The following is a description of a gene set: studied in species Homo sapiens Genes having at least one occurence of the motif CATTTCA in their 3' untranslated region. The motif represents putative target (that is, seed match) of human mature miRNA hsa-miR-203 (v7.1 miRBase). Human Gene Set: CATTTCA_MIR203, and this is the list of marker genes: SLC7A14, GPATCH1, CHST7, CAPN3, CPEB4 (cytoplasmic polyadenylation element binding protein 4), DPY19L4, INA, PLAA, COL17A1, IGFBP5, ELL2, KRT35, ANP32E, ZNF532, XKR6, APRG1, GLRB, BTBD7, RPGRIP1L, ID4, RERG, WDFY3, OSBPL8, OVOL1, ETS2, BMERB1, SRSF1, EGR3, PRICKLE2, PRKCA, TMEM248, ATG14 (autophagy related 14), KHDRBS1, KRT85, TRPV3, AP1G1, PDE4D, NAA25, NUFIP2, CSNK1A1, RAPGEF4, NXPH1, HIPK1, ACO2, SOSTDC1, KIAA0930, MAGI1, LAMP2, API5, ALDH1A2, SEC24D, PURB, CCDC178, PTPN3, CTDSPL2, YWHAQ, ATP5MC3, CITED2, XPO4, LIMCH1 (LIM and calponin homology domains 1), SESTD1, ITPR2, SLC1A2, EPC2, GPR180, ID2B, APPL1, PTPRG, ABL1, PLD2, ETV1, SPIRE1, NDRG3, EIF4E, STX16, KLF12, PRKG1, NBEA, PRPS2, UBR3, CCNG1, KRT1, AFF4, TAF1D, RAB10, MACIR, HYCC2, TRPS1, BMAL1, RAP1A, MORF4L1 (NCBI Gene Id 10933), XYLT1, DCUN1D3, ACVR2A, FERRY3, PPP1R12A, CUL1, RAPH1, SRC, MBLAC2, STEAP1, DYRK1A, CLRN1, VAV3, CLUH, ARID1A (NCBI Gene Id 8289), SEPTIN3, CSRNP2, SPEN, AFAP1L2, GRHL3, ADAMTS6, ZFC3H1, VCAN, NUMBL, DGKB, NKRF, ID2, NUAK1, SLC12A2, EGR1, SLC39A9, GLCCI1, TASP1, CDH10, RARB, BPTF, NAA30, RNF38, TWF1, KIF2A, SMAD1, ZRANB2, SMURF1, AHR, R3HDM1, CCNC, MBD6, LRRC37A6P, SOCS6, SYNJ1, NLK, KCTD9, GNAO1, EBF3, DUSP5, FOXG1, FMNL2, ATP2B2, PDAP1, FOXK1, H3-3A, APC, TSC22D1, VAT1 (NCBI Gene Id 10493), MEX3C, MAP4K3, DGKZ, KPNB1, AP2B1, NEGR1, VAPA, PDSS2, XRN2, FOXK2, SGK3, NAA50 (NCBI Gene Id 80218), RNF34, CAB39, SIK1, ATM, EGLN1, CREBZF, SOCS3, PLPP3, SLC4A4, ZMIZ1, PCDH19, TUSC2, MBNL2, PRKCB, CLASP2, INSIG1, PCSK1, ZMYM4, LMBRD2, SPTSSA, ABCE1, DGCR2, YTHDF3, DNMT3B, PRPF19, CREBRF, TIAL1, PLEKHG3 (NCBI Gene Id 26030), FKBP5 (FKBP prolyl isomerase 5), SRSF10, FAM228A, AP1S2, CAPRIN1, KMO, ZNF281, FMR1, PCSK2, PPP1CB, JOSD1, AMOT, GLI3, C1orf122, DDX6, ZFAND6, RPS6KA3, ARHGAP12, PHF12, GABRB3, DR1, MORF4L2, GABARAPL1 (GABA type A receptor associated protein like 1), ADK, GALNT17, YPEL4, ZNF608, ATP8B5P, GABRB2 (gamma-aminobutyric acid type A receptor subunit beta2), HOOK3 (hook microtubule tethering protein 3), CSNK1A1L, WTAP, KDF1, TMTC2, ARID2, CSN2 (casein beta), TAF5, FBXO43, SP4, DLG5, NR4A3, NPAS4, TENT5A, DNAJC21, BCL11B, BCL7A, MAFK, PHLDA3 (pleckstrin homology like domain family A member 3), RALB, RAB8B (NCBI Gene Id 51762), MAPK9, GPR85, EN2, SPARC, LPP, HOXA1, LPIN1, LASP1, IRS2, MYEF2, TSHZ1, TCF12, ZMYND11, TNFRSF8, TMEM100, TNRC6B (NCBI Gene Id 23112), COPS7B, NOVA1, SOX13, EDN1, ABHD14A, NMNAT2, TARDBP, ISL1, MEF2C, MBNL1, SEMA5A, AKIRIN1, SEC62, SLC17A6, MECP2, UBR1, PTP4A1, NR2C2, SELENOT, DLX5, MED14, BICRAL, HNRNPL, CCDC15, PHF19, PSME4, PPM1B, CNTFR